Given this list of marker genes Chpt1, Cept1, Pcyt1b, Chkb, Pcyt1a, Chka, here is a description of the gene set: Mouse Gene Set: GOBP_CDP_CHOLINE_PATHWAY studied in species Mus musculus The phosphatidylcholine biosynthetic process that begins with the phosphorylation of choline and ends with the combination of CDP-choline with diacylglycerol to form phosphatidylcholine.